Given this list of marker genes GPRC5C, MAIP1, RNU5E-4P, NCAPG, C16orf46, CEP170, CNTNAP2, ERCC4, KRR1, NUP58, CYRIB, DEDD2, ZSWIM1, CD109, TMEM199, ZFYVE1, TMEM94, ZFP91-CNTF, WBP2, WEE2-AS1, TAF2, TTC6, PIH1D1, RSPH1-DT, SLC8A1-AS1, LIN37, RN7SL418P, CLP1, RAB7A (RAB7A, member RAS oncogene family), HIVEP3 (HIVEP zinc finger 3), C6orf226, POLR2B, SPSB3, RAD51D, FEZ2, RPTOR, PPFIBP2, ZNF138, HM13, PNPLA6, ARHGDIG, SUPT4H1, SPATS2L, ZNF436-AS1, MED10, DHDDS, MTMR2 (myotubularin related protein 2), H3C4, AIMP1, ZSCAN5A, MAP4K1, CNPY2, RPSA (ribosomal protein SA), MRPL19, ZSWIM8, CEP41, HDAC9, PSMG2, GPR107 (G protein-coupled receptor 107), IQCH (IQ motif containing H), MACROD1, CUTA, ERAL1, DFFB, UTP18, ENSG00000259403, LINC02832 (NCBI Gene Id 105373886), POLR2J4, GMPR2, METTL15, ACYP2, CKMT2-AS1, DHX35, SNHG10, ERAP1 (endoplasmic reticulum aminopeptidase 1), AHSA1, IFTAP, ERCC2, LUC7L2, PTBP1, UTP25, CCDC38, MYL6, NRP2, NFIC, RBM22, RSPH1, RBM6, ZNF250 (NCBI Gene Id 58500), CEP76, NFKBIZ, ARHGEF1, TMBIM1, NPIPB8, IFT70B (NCBI Gene Id 150737), TMEM258, USP42, TP53RK-DT, USP40, SLC35C1, ABT1, MRPS25, CCDC86, RNU11, CAND1, C6orf141, ZPR1, NIF3L1, SLC35B1, TCF3, SLC35A3, HOXA7, TECR, SOX6, PTMA, NPC1, ENSG00000248636, MYL12B, GRHL2-DT, MMADHC, SEC23IP, TTC14, TIAM1, PPM1F-AS1, PDE7A, KLHL7-DT, DFFA, SET, RSBN1, TRIM31, MRTO4, CYP2R1, KHSRP (KH-type splicing regulatory protein), SNRPF-DT, POP4, LAMTOR5-AS1, DNAJC17, DNAJC14, LINC00598, SLC30A10, PHB2, KIF18A, PRR13P5, APTX, ARHGAP26, RNVU1-21, CCDST, DDX42, SMAD7, FUBP3, BCAR3, DTNB, EPCIP-AS1, HSPB3, SNRNP40, WDR62, SPC25, HAPSTR1, EXOC8, KIAA1191, NOP56, SLC4A1AP, PSEN1, NUCKS1, MIR22HG, FRMD5, LRP10, SUPV3L1, FAF1, NR2F2-AS1, MAPKBP1 (NCBI Gene Id 23005), MRPL30, ALKBH7, DYNC2I1, GAS5, PRCC, SLPI, MED29, NDUFB4P2, CEP112 (centrosomal protein 112), CD55, CPEB4, PCBP1, MAP3K5, ENSG00000249236, INO80B, ZNF860, MVB12A, TRIB1AL, ZNF436, HOXB8, CENPT, TIAL1, MAN1B1-DT, IDH3B-DT, RNU5B-1, GFM1, HSD11B1L, DHX30, NME1-NME2 (NME1-NME2 readthrough), HYKK, TMEM208, EMC6, ACBD4, C1orf226, CLDN7, FRMD4B, PPP1R13L, BLOC1S3, PRKAR1A, TOR4A, CAPG, MIR5087, MMACHC, CLRN3, ATPAF2, SHH, TMEM161B-DT, RFX2, METTL4, METTL25, SERGEF, SLC30A4-AS1, ADAP1, PRKRIP1, MICOS13, VPS50, ENSG00000187186, SCARNA2, RNU6-450P, ACTR1A, DPH6-DT, PAPOLA-DT, DRAIC, MACO1, NDC80, XPNPEP1, NUBP2, SMCHD1, UBE2D3-AS1, CADM1, BAZ1B, METTL3, VWA8, COL4A2, TRIM69, KIAA0319, RNF39, GOLGA4, PTX3, COL7A1, SMARCAL1, NID2, ID2-AS1, YTHDC1, ARNT, RAB11A, STRIP2, STK3, LINC01111 (long intergenic non-protein coding RNA 1111), MICU1, SNX3, NR1H2, PDCD1LG2, PEX12, TGDS, ACOT8, STYK1, MEST, COX7A2, CCDC18-AS1, ATP6V1D, NTNG1, LRRC8A, TANK, ZNF785, HOXA10, PPP2CA, GMDS, THADA, CCDC175, INO80B-WBP1, PLEKHB2, DSG1-AS1, MAN1B1, RBM27, GOSR2-DT, ARL6IP1, WDR74, RNU6-107P, POLG2, PSMC4, EPM2AIP1, CLN3, AURKA, HMGN2P46 (high mobility group nucleosomal binding domain 2 pseudogene 46), NUDCD3, ZNF213, CIB2, CYP4F12, SDF2L1, LRP6, THSD4, LINC02441, LPP, ISY1, PHF23, TIMM8B, MRPL47, STK11IP, ACOX1, TUBG2, CLDN4, TUBB2B, MGST1, QTRT2, SUPT7L, ABI3BP, RPL8, CRACR2B, THAP1, LINC02331, TMEM38A, DNAJC16, ELP3, RPLP2, DNAJC7, SNX1, ALKBH8, CALR3, LARGE1-AS1, VILL, TFIP11-DT, ENSG00000253824, SUGCT, SF3A2 (splicing factor 3a subunit 2), ZNF408, ILF2 (NCBI Gene Id 3608), WDR36, RAB4B, THBS4, RNU4-86P, ADGRG6, CDH17, RPL26L1-AS1, BCAT1, TFEC, ARPP19, FAM114A2, GTPBP8, DCUN1D4, KBTBD6, SMIM7 (small integral membrane protein 7), SNRPF, CGGBP1, COX14, RNU6-952P, FZD3, TEF, MLLT3, CHD1, KMT5C, SIRT2, NFIX, TADA1, HDAC8, GTF2H1, ATAD2, BUB1B, KANSL1L, SNX17, PRDM1, TTF2, PSMD7, CCDC191 (NCBI Gene Id 57577), NFIB-AS1, PDE11A, MIS12, HNF4A (NCBI Gene Id 4339), ZNF552, SENP1, GUCY2C, SECISBP2, NDUFA3, LINC03017, SRSF10, L3MBTL2 (NCBI Gene Id 83746), RPL7AP82, SKP1, PPARG, WDR83OS, UGT2B7, RPLP0 (NCBI Gene Id 6175), AREL1, ZNF131, GTF2B, EDC3, TRPM3, ANKRD24, SDCCAG8, SHPK, CLPX, STK19, KBTBD7, DUT, EIF2B4, PAK1IP1, PRIM2, MED23, INKA2, SMAD3-AS1, TXK, SFXN5, KCTD16, MIR4682, VPS41, FMC1-LUC7L2, TMEM150B, POLR2M, FAM228B, ADAMTS7P4, DLD, SCAF1, UNC45A, MRPL24, CAPN8, MVK, WDR83, PTGES3, LINC01133, PMF1-BGLAP, NOL8, MANBAL, TBCK, NUP54, DDX47, GFM2, POU2AF1, SLC12A9, NNT, CDCA8, KIF3B, NEURL4 (neuralized E3 ubiquitin protein ligase 4), EEF1A1, ZNF526, LRPPRC, CACYBP, CUX1, CEACAM1, COPE, SRSF3, PEMT, RNU5E-6P, CDCA5, RPGRIP1L, CDC27, CCDC15, MRPS14, SIRT3, PMPCB, TRIP4, CENPU, GTF2H4, ZFP91, ZNF302, LINC02889 (long intergenic non-protein coding RNA 2889), PCLAF, MACC1, FTSJ3, RPL26L1, GPR108, FAM185BP, WEE1, PACRGL, ISG20L2, MYO9B, TTC22, UBB, CFDP1, PAPOLA, GIRGL, NRDC, NAA35, TOX4, NSUN6, CHMP4B, CASP8, RXRB, TMEM101, LINC01767, LINC02458, SLC1A5, GLYCTK, LCMT1-AS1, TRIM15, TIPARP-AS1, ADORA1, ASTE1, LINC00310, ZFP36, LTBR, PLSCR3, RNU4-2, CDIPTOSP, LAPTM4A (lysosomal protein transmembrane 4 alpha), ITGB5, PRKCSH, DDX49, TUFT1, HOXA9, CENPK, PPM1L-DT, SNORA21, NEDD8, TSPAN1, ZNHIT2, AQR, STIM2-AS1, KDM1A (NCBI Gene Id 23028), TARS2, PTS, ABTB3, CDH3, SNORD68, ALG1, C11orf24, FBXL9P, MAP1S, CCDC163, RANBP2, BLTP3B-DT, PXN-AS1, UBE2D3, HAUS4, ENPP3, NDUFS5, ENSG00000267174, ZSCAN22, TMEM39A, PRPF31, BCAS3, MRPS15, THAP11, MET, BCL11A, RDH13 (retinol dehydrogenase 13), PCBP1-AS1, LINC01363, HAS1, RALGAPA2, SZT2, NDUFAF6, EGLN3, GLI1, ECT2, STARD10, VMP1, TYW5, SYTL2 (synaptotagmin like 2), MIR3681HG, ZNF443, MITD1, EHD1, APPL2, MAP3K3, ZFYVE19, MAPKAPK3, RPL13, MCMBP (minichromosome maintenance complex binding protein), TM7SF3, ZCCHC4, LINC02960, ATG5, ACTB, CCDC159, TLE4, TEDC1, CATIP-AS1, EIF3K, NOL6, MRPS33, PIP5K1B, TTC14-DT, LCMT1, RFTN1, ZNHIT3, CCDC174, GARIN5A, CYTIP, OSBPL10, GOLGB1, GABPA, ANKRD40CL, PIGC, ADGRA3, TRMO, PPP1R12C, CCT6B, CDKN2C, ISG15, PICK1, NHLRC3, PJA2, MFAP3, ZBTB37, NADK, FADS2, LINC02709, ATP10B, RAB1B (NCBI Gene Id 81876), ZNFX1, GAREM1, XIRP2-AS1, TMED2, PRPF18, BRAF, KYAT1, CYB561A3, CCDC66, MBP, RBM41, DAXX, ZNHIT1, MIR8059, MRPL44, EFNA5, USP11, CLK2, HNRNPA3, NMT1, METTL14-DT, IFRD2, PM20D2, WNT5A, PIGO, PAF1, DNAJB1, BAG4, NAPA-AS1, MSMP, ADAM15, LINC01089, CYP1B1, GARS1, PLAUR, PAXBP1, RPL7L1 (ribosomal protein L7 like 1), AIMP2, DDX27 (DEAD-box helicase 27), TMEM170A, PRPF6, PDGFC, ENSG00000198491, BMS1P4-AGAP5, KDM4B, PGS1, EFCAB7, ABHD2, NUDT3, ENSG00000275740, OSBP, CFAP69, NIFK-AS1, CDC6, MYBPC1, GGCX, GBA1, TGFBR2, SCIRT, SLC38A9, C19orf44, LINC01719, FAM222B, PSMB6, STK31, MIR4495, CCDC192, PRKAB1, PSMC2, ZER1 (zyg-11 related cell cycle regulator), SMCO4, TOM1L2, LTBP1, TBC1D16 (TBC1 domain family member 16), ZFPL1, FAM200A, SPINK5, LINC02747, DNAH11, VIPAS39, MSI2, PGAP3, EXOSC8, ICE1, PFKM, TRA2A, ZNF213-AS1, ENSG00000253270, FOCAD, PTPRO, ITGA1, VPS51, CHCHD6, ADGRF4, C1orf21, SLC30A5, ALDH18A1, KIF1B, GPR160, ABCC3, SF3B6, ANKRD11, HECW2-AS1, NR5A2, ALG5, USP48, SGK1, CFAP418, ALKBH2, TAF13, SLC26A11, NXN, MRPL1, YJU2, YWHAE, PRR15, TP53RK, ANKAR, KCNK6, TRAPPC3, CYP51A1, UBE2F-SCLY, ZNF608, MRPL9, EXO1, ITFG2-AS1, REXO2, SEC24C, WTAP, CXCL2, WDR46, NRP1, TOGARAM1, CYB561D2, CSGALNACT1, ERCC5, ENC1, DNAJC2, SDR16C5, CLASP1, UTRN, FAR1-IT1, ZNF324, NSA2, DEDD, FAM47E, CPOX, EFL1, LAMTOR5, CDNF, GDAP1, PLEKHJ1, TXNDC12, RPS9, UNK, PTPRD, ZNF589, MRPL46, CCNI, ZSCAN5A-AS1, RXFP1, BRMS1, ASAH1-AS1, PSMD8, SMC1A, CUL5 (cullin 5), IRGQ, GSX2, LINC01411, TPD52L2, ASAH1, MRPS22, SPRTN, LINC02924, WDR82 (WD repeat domain 82), LRATD2, METTL26, OAZ3, AMOTL2, RPS26, TRAPPC6A, VRK1, PSMG4, ODAD3, DUS2, ZNF17, KPNA1, BCL6, PMS2, MIR759, EIF2S1, MYO10, ATP5PF, NR4A2, MPLKIP, BMS1, C6orf52, VPS26B (NCBI Gene Id 112936), ERH, PBX1, VTRNA1-2, NUP160, PTCH1, NOP53, PPP1R21, TMEM123, LAPTM4A-DT, SYT9-AS1, N4BP1, ISCA1, LINC02261 (NCBI Gene Id 101929199), FAM76A, NGDN, LONP2, NDC1, TSPAN12, HGD, PCCB, GLRX5, NAGPA, GINS3, CASP9 (NCBI Gene Id 842), EOLA1-DT, NCAPD2, HOXB4, SMYD3, SATB2, DNAH7, BCL2L14, HUS1, CCDC25, TNK2, CRYZL1, MIR100HG (NCBI Gene Id 399959), SAMD10, LAD1, FCF1P7, ABR, CFLAR, NUP155, PSMD13, SH2D6, NXT2 (NCBI Gene Id 55916), PLEKHA8P1, RNF145, VCPIP1, SDCBP2, MYL6B-AS1, HAUS3, SIX5, IL13RA2, RTTN, PEX26, SCML1, KAZN, EGFR, EPHA4, FDXR, LINC01778, ST20-MTHFS, CLNS1A, DST, KLC2-AS2, KIF21A, BBX, CCDC59, NDEL1, NFKBIB, CSNK1G1, VXN, SETDB1, ZNF143, PIGO-AS1, CCDC9, DMXL2, KPTN, MCRIP2, RNF44, CEP83, KDM4A, IFT140, WDR59, KCNIP2, MBTD1, MTUS1-DT, HEPH, IGF2BP3, PPM1G, TFIP11, GID4, RPL13A, YPEL5, BET1L (Bet1 golgi vesicular membrane trafficking protein like), FZR1, LARS2, CEP104, PRR15L, SSBP1, LDHA, ALDH1A2, RPS14, TPK1, MRPS11, SMG6, ZC2HC1C, PDE7A-DT, EVI5L, RAB2B, FTO, ENSG00000221139, NR1D2, CHN1, THAP8, TRD-AS1, GUSBP11 (NCBI Gene Id 91316), RIC8A, CDC42SE1, ZNF821, IFNGR1, RPS17, UBLCP1, UQCC4, KRT18, DXO, SNORD12C, NOA1, TBC1D5, POLR2K, ENSG00000233230, CTDP1, HMG20A, ZBTB40, HSPA14, SIM1-AS1, RN7SL346P, RSPH3, TBC1D32, MYLK-AS1 (MYLK antisense RNA 1), GORAB-AS1, HOXA-AS2, PIN4, GSE1, NUP35, LINC02410, FAM227B, GREB1L, LAMA3, EMC10, ZNF106, DMKN, CDCA3, C16orf46-DT (NCBI Gene Id 128266836), KRTAP4-9, NEAT1, IDH3B (NCBI Gene Id 3420), GOSR2, PFDN6, SNRNP200, MIB2, SNX30, ISY1-RAB43, DIAPH1, XPC (XPC complex subunit, DNA damage recognition and repair factor), PPIG, C12orf57, ACAD9, PRR7-AS1, ZCCHC7, NUTF2, DYNC2I2, TMEM126A, C3orf38, PLS1, PPP2R5B, CAPZA2, MCTS2 (NCBI Gene Id 100101490), SNX11, PRLR, GABPB2, LSM8, TTC28, HEXIM2-AS1, RFFL, CDKN1B, MRPL13, RPL36 (ribosomal protein L36), ZNF23, H3-3B, BMS1P4, SKA3, CDIN1, ATP5MC2, SLC39A7, RPL32P3, LINC00649, SCP2, LRFN3, UBE2F, DENND4A, GSDMD, AIRIM, SNAP23, MPPE1, IQCN, TMEM138 (NCBI Gene Id 51524), PPWD1, C5orf52, RN7SKP193, EFCAB5, NEDD8-MDP1, FOXD1, CHMP7, ABCB8, CALCOCO1, LINC02243, TMEM102, SLC37A1, POLN, SRI, TMEM198B, HOTTIP, PPM1L, SAMD4B, PSMB5, MPV17L2, SMG5, RPS6, WDPCP, WSB2, GLUD1P3, SERBP1 (NCBI Gene Id 51624), RTRAF, NDUFB4, CIRBP, FHL1, STARD3NL, MLIP, TMEM108-AS1, ITSN1, IST1, AHCYL2, ZNF391, PRKCI, PDXP, CDC14B, ZNF341-AS1, AFG1L, TMC3-AS1, PLOD3, EMG1, AADACP1, FAM110A, TNIK, ARMT1, CHRNB1, DCAF16, DYRK4, LINC03011, EIF3E, AIDA, KMT5A, RNU6-316P, ENSG00000259072, SDHD, NHEJ1, METTL8, NBPF1, STIM2 (NCBI Gene Id 57620), ZNF79, ENSG00000265751, AMN1, DTWD1, CASP4, LINC02024, RMND1, TM4SF4, KLHL7, ZNF830, CCNB2P1, SAMD1, PKIB, TRIP12, DRC3, CCDC126, ZNF674-AS1, TIPARP, LSM1 (LSM1 homolog, mRNA degradation associated), AP3S2 (adaptor related protein complex 3 subunit sigma 2), RAB26, GRHL2, LINC01275, CTU1, PORCN, ZNF143-AS1, ECI1, TMEM79, FAM168A, PRCP, MYO5B, LINC00687, POLDIP2, BOD1L1, E2F2, BTF3L4, LIMCH1, EOLA1, USP54, TXN, CARD14, SP1, ZCCHC14, RAPGEF6, CCDC93, NPRL2, ZCCHC9, CENPP, HMGB3P22, EMC1, SLCO2B1, TRIP10, NKIRAS1, CDK13, SH3D21, METTL25B, MTRF1, FEM1A, AAGAB, PEAK1, SNHG17 (small nucleolar RNA host gene 17), ARHGAP29-AS1, LIMA1, TMEM115, ITGB3BP, TRBV30, FAHD2A, ZNF181, NAP1L4, CWC22 (NCBI Gene Id 57703), ZNF497-AS1, ZNF251, HAUS8, GAPDHP25, MFSD11 (major facilitator superfamily domain containing 11), SPATS2, PPIL3, IMMP2L, DISC1, SIRT6 (NCBI Gene Id 51548), ANXA2, RPL23, LMAN2, ERBB2, SRRM5, SNRPC, KIF14, ELL3, RFC4, RPL29 (NCBI Gene Id 6159), FMC1, PIERCE2, MRPL51, MIR7-2, APH1B, LINC00265, LRP1, TMEM41A, CTNS, VPS4B, YIPF5, DBNL, RPP30, PAFAH1B2, ARHGAP32, PROSER1, PMF1, TMEM14A, LINC02547, CASD1 (NCBI Gene Id 85885), ZNF473CR, SETD9, RPL24, TNFRSF10B, FEN1, NEDD1, VAMP8, IER3-AS1, NCAPD3, RRP15, MLH1, OSCAR, KLHL28, EPHA1, ENSG00000246308, PALM3, DRG2, PANK3, COX15, ZNF576, LINC01619, SLC30A6-DT, PACS1, MDH1, FLOT1, IDUA, CDC42EP4, CLTC, PAFAH2, C9orf72 (NCBI Gene Id 73205), SURF6, RAB27A, SCHIP1, COX7A2L (NCBI Gene Id 9167), CAPN10 (calpain 10), YAE1, EXOSC7, PCBP2, UQCC1, SLC39A9, JOSD2, UFC1, NXPE2, ZMAT2, TAF3, MIR5091, KBTBD6-DT, PRKCH, BBIP1, CHSY1, ACTL6A, TFPT, EIF4G2, TPR, EPS15-AS1, ARHGAP1, ATG101, DGKQ, ZEB2, RPS29P16, SHOC2, PCSK9, STAT6, HTATSF1, RPS13, DCAKD, PSME3, PABPN1, CDC14A, UBE4A, VASP, PNLIPRP1, CRYGC, TRMT10C, STARD5, MTMR11, HEXIM2, SMIM31, KAT7, ELOC, CCDC146, ILVBL, LPXN, RHOF, ZCCHC17, DMXL1, POU2F1, MED8, PSMC5, RNU4-1, SCYL3, PSMG3, FAM53C, SLMAP, ZFAS1, C1orf105, C1orf56, TYMS, UQCR11, NWD1, GABARAP, SUCLG1, STEAP2, VAMP1, RNU6-1276P, ODR4, DDX18, CLPTM1, DCAF17, ST20, PIDD1, PIWIL2, FCF1, VPS53, NACA4P, SLC30A6, RHCE, PSME2P3, SCAND2P, SNHG15, LINC01392, HIKESHI, ANKRD13D, ZNF337, HDGF, AMDHD1, ZNF3, CFI (complement factor I), TSG101, SYTL5, METTL14, PAIP2, NME1, PHF8 (PHD finger protein 8), SLC11A2, NDUFB5, ZFP36L2, LINC01412, FRYL, TNFRSF14, NDUFA11, BROX, ZSWIM3 (NCBI Gene Id 140831), DROSHA, POLR1G (NCBI Gene Id 10849), TMEM161B (NCBI Gene Id 153396), OR13C2, TBC1D22A (TBC1 domain family member 22A), DCP1A, LTN1, USP22, SLC37A4, MYCL, NUDCD1, KRT8, RNU5A-1, SERINC1, RIBC1, CDK12, ADO, UBXN8, PIM1, EGR1, OR10J2P, CDKAL1, NSMAF, CEP170B, CDK8, HACD2, TBRG4, CANX, MED15, PPP1R12B, MAGI1, CSTF1, TOR3A, TAGAP-AS1, DENND3, MTBP, CCPG1, PPM1H, PTK6, TM2D1, NCLN, BOLA1, HPS5, CYB561D1, BCL2L13, ZDHHC5, MEMO1, PPP1R42, FBXO36, RPL7L1P8, SLC28A2-AS1, HOXA-AS3, DESI2, SYT8, PHB1, ANGEL1, SLC38A11, CGRRF1, SAMM50, AARS2, ENY2, TMEM70, ZNF674, LMO7, ZC3H12D, AADAT, TJP2, RPL7P30, CUTC, MLLT10, PPOX, C7orf50, PGM3, CDIPT, SLC35B4, HCG14, MIR5700, VMAC, HES4, HCFC1R1, REG4, H2AX, SIAH1, ZNF217, PPRC1, TCTN3, RPL39P40, TMF1, RPL37, HNMT, SLC7A11, MIR194-1, RGS9, SMIM30, PPP2CA-DT, RPS27, HGSNAT, DERL2, CCDC47, RNA5SP473, VARS2, HOMER1, CDH26, KHDC4, TBL3, here is a description of the gene set: species: Homo sapiens Human Gene Set: LHX2_TARGET_GENES from publication Yevshin I, Sharipov R, Kolmykov S, Kondrakhin Y, Kolpakov F (PMID 30445619) Genes containing one or more binding sites for (LHX2) in their promoter regions (TSS -1000,+100 bp) as identified by GTRD version 20.06 ChIP-seq harmonization.